Given this list of marker genes CYP26C1, RDH11, DHRS3, ADH4, ALDH1A1, ADH1C, ADH1A, CRABP1, DHRS9, RDH13, CYP26B1, RDH16, RDH5, ALDH8A1, AKR1C3, ALDH1A2, CYP26A1, ALDH1A3, SDR16C5, RDH10, RDH14, DHRS4, here is a description of the gene set: Reactome Pathway: RA biosynthesis pathway part of: Signaling by Retinoic Acid The major activated retinoid, all-trans-retinoic acid (atRA) is produced by the dehydrogenation of all-trans-retinol (atROL) by members of the short chain dehydrogenase/reductase (SDR) and aldehyde dehydrogenase (RALDH) gene families. species: Homo sapiens